The following is a description of a gene set: Mouse Gene Set: MIR_6975_5P studied in species Mus musculus Genes predicted to be targets of miRBase v22 microRNA mmu_miR_6975_5p in miRDB v6.0 with MirTarget v4 prediction scores > 80 (high confidence targets). from publication Chen Y, Wang X (PMID 31504780), and this is the list of marker genes: Lypd6, Hspa12a, Fgf18, Numa1, Agtr1b, B3galt1, Crhr2, Lzts3, Zfx, Ermp1, Mllt11, Niban2 (NCBI Gene Id 227737), Naa40, D6Ertd527e, Krtap5-2, Pxn (NCBI Gene Id 19303), Gpr37l1, Selenon, Tent4b, Fancd2, Capn12, Sidt2, Otub1, Rfng, Dcun1d3, Magi1, Scd1, Nr1i3, Aqp9, Elmod1, Ptprf, Adcy9, Mal2 (NCBI Gene Id 223579), Igsf9b, Lbh, Zranb2, Vav3 (NCBI Gene Id 99531, vav 3 oncogene), Pou3f3, Fggy, Zbtb4, Mcpt1, Kcnma1 (potassium large conductance calcium-activated channel, subfamily M, alpha member 1), Plagl1, Prom2, Mtrf1l, Skint3, Cd320, Phactr1, Prkar1b, Sfxn1, Kcnk3, Slc25a40, Rbmx, Tanc2, Ubiad1, Alkbh6, Dpp10, Tbkbp1, Fbrs, Elf5, Hmox1, Nr6a1, Tnrc6b, Shisal1, Pin1, Fbxl20, Psmd8, Dhx33, Tbc1d15, Itga5 (integrin alpha 5 (fibronectin receptor alpha)), Mecp2 (methyl CpG binding protein 2), Stk25, Vat1, Vwa8, Rab6b, Eda, Tmem209, Eipr1, Tspan2, Fbxl17, Hepacam, Atp8b2, Sh3pxd2a, Nsd1, Iqsec3 (IQ motif and Sec7 domain 3), Cyp2s1 (cytochrome P450, family 2, subfamily s, polypeptide 1), Mpdu1, Rnf20, Meis2, Xpo7, Dennd11, Cdk5r2, Cic, Eeig1, Pggt1b, Arfip1, Rnf44, Lrsam1 (NCBI Gene Id 227738), Atxn1l, Plxna1, Sox6, Pskh1, Mat2a, Mical2, Ccna2, Spart, Dagla, Csmd2, Heyl, Ehd2, Ccdc178, Tet3, Adam19, Kdelr1, Ccdc97, Mad1l1, Cdr2l, Scimp, Slc25a42, Kcnj10, Gab2